The following is a description of a gene set: species: Homo sapiens Mitochondria are vital for cellular bioenergetics and play a central role in determining the point-of-no-return of the apoptotic process. As a consequence, mitochondria exert a dual function in carcinogenesis. Cancer-associated changes in cellular metabolism (the Warburg effect) influence mitochondrial function, and the invalidation of apoptosis is linked to an inhibition of mitochondrial outer membrane permeabilization (MOMP). On theoretical grounds, it is tempting to develop specific therapeutic interventions that target the mitochondrial Achilles' heel, rendering cancer cells metabolically unviable or subverting endogenous MOMP inhibitors. A variety of experimental therapeutic agents can directly target mitochondria, causing apoptosis induction. This applies to a heterogeneous collection of chemically unrelated compounds including positively charged alpha-helical peptides, agents designed to mimic the Bcl-2 homology domain 3 of Bcl-2-like proteins, ampholytic cations, metals and steroid-like compounds. Such MOMP inducers or facilitators can induce apoptosis by themselves (monotherapy) or facilitate apoptosis induction in combination therapies, bypassing chemoresistance against DNA-damaging agents. In addition, it is possible to design molecules that neutralize inhibitor of apoptosis proteins (IAPs) or heat shock protein 70 (HSP70). Such IAP or HSP70 inhibitors can mimic the action of mitochondrion-derived mediators (Smac/DIABLO, that is, second mitochondria-derived activator of caspases/direct inhibitor of apoptosis-binding protein with a low isoelectric point, in the case of IAPs; AIF, that is apoptosis-inducing factor, in the case of HSP70) and exert potent chemosensitizing effects. Proteins that permeabilize mitochondria. from publication Galluzzi L, Larochette N, Zamzami N, Kroemer G (PMID 16892093) Human Gene Set: GALLUZZI_PERMEABILIZE_MITOCHONDRIA, and this is the list of marker genes: SHC1, BAK1, DNM1L, CPT2, BAD, PLS3, GZMB, CASP3, VDAC1, SH3GLB1 (SH3 domain containing GRB2 like, endophilin B1), MTCH2, NR4A1, MCL1, PPID, BCL2, H1-2, BBC3 (NCBI Gene Id 27113), SIVA1, BID, BCL2L11, TP53, MOAP1, GZMA, GCK, BAX, PMAIP1, CASP2, BCL2L1, STK11, GSK3B, BNIP3, SOD2, ABL1, FDXR, CLIC4, SERPINB5, PRODH, CFL2, VDAC2, PRKCD, MAPK8 (NCBI Gene Id 5599)